Given this list of marker genes Nectin3, Cxadr, Ptprd, Lgals9, Cadm3, Colec10, Ceacam5, Nlgn1, Cbln1, Sele, Cd6, Tenm2, Selp, Adgrl1, Itga4, Jaml, Grid2, Scarf2, Crb1, Alcam, Hmcn1, Nectin4, Umod, Amigo1, Mcam, Cd164, Amigo2, Fat4, Crtam, Cadm1, Vcam1, Cdh4, Il1rapl1, Dchs1, Cdh2, Itga5, Sell, Lgals1, Itgal, Nrxn1, L1cam, Cd24a, Crb2 (crumbs family member 2), Pvr, Amigo3, Nectin1, Scarf1, Igsf21, here is a description of the gene set: Mouse Gene Set: GOBP_HETEROPHILIC_CELL_CELL_ADHESION_VIA_PLASMA_MEMBRANE_CELL_ADHESION_MOLECULES The attachment of an adhesion molecule in one cell to a nonidentical adhesion molecule in an adjacent cell. species: Mus musculus